Given this list of marker genes Rbm14, Zic3, Leo1, Bmp4, Wnt5a, Paf1, Il1rn, Tenm4, Vangl2, Acvr2b, Grb2, Gja1, Bmpr1a, Gata6, Eomes, Nat8f3, Tasor, Nf2, Dkk1, Apoa1, Tal1, Gata4, Col5a2, Lbx2, Map2k1, Frs2, Col11a1 (collagen, type XI, alpha 1), Dact1, Rtf1, Sfrp1, Hhex, Lrp5, Arfrp1, Nog, Col5a1, Kdm6a, Kdm6b, Ets2, Apln, Nr4a3, Scx, Clasp2, Armc5, Elf5, Smad2 (SMAD family member 2), Nphp3 (NCBI Gene Id 74025), Txnrd1, Myadm, Dusp5, Eya1, Dld, Ctnnb1, Ext1, Bmp7, Gpi1, Apela, Prickle1, Amot, Arid1a, Setd2, Hand1, Chrd, Rps6, Smad1, Mesp2, Nsd1, Hnf1a, Col4a2, Fzd7, Hnf4a, Foxf1, Prkar1a, T, Tgif1, Wnt3a, Klf4, Poglut1, Sox17, Zbtb17, Acvr2a, Dab2, Tbx19, Dag1, Aplnr, Nckap1, Pofut2, Ric8a, Col6a1, Macroh2a1, Vtn, Mmp2, Nat8f5, Sox2, Tbx6, Itgb3, Wls, Dusp1, Atoh8, Srf, Wnt5b, Tgif2, Hsbp1, Mesp1, Foxa2, Il10 (NCBI Gene Id 16153), Phldb2, Taf10, Mmp9, Acvr1 (NCBI Gene Id 11478), Dusp2, Nat8f2, Fgf8, Wnt3, Itga5, Foxc1, Tcf3, Snai1, Dvl2, Prkaca, Nat8, Hmga2, Hnf1b, Pax2, Dvl1, Gpc3, Msgn1, Inhba, Nr0b1, Itga3, Cul3, Kif16b, Itga8, Mmp15, Itga2, Tnfaip3, Lhx1, Fgfr1, Lmbrd1, Sfrp2, Ecsit, Htt, Myh9, Lamb3, Smad3, Mmp14, Trp53 (NCBI Gene Id 22059), Lef1, Mbp (myelin basic protein), Pou5f1, Ctr9, Clasp1, Lefty1, Lrp6, Map2k5, Nodal, Gdf3, Macf1, Mixl1, Cer1, Syf2, Itgb4, Rnf2, Ahdc1, Megf8, Ugdh, Col12a1, Dusp4, Etv2, Foxc2, Epb41l5 (erythrocyte membrane protein band 4.1 like 5), Adipoq, Brd3, Twsg1, Bmpr2, Epha2, Osr2, Cfc1, Axin1, Rack1, Sox7, Otx2, Itgav, Zfp568, Cripto, Crb2, Ldb1, Tnrc6c, Ext2, Tgfbr2 (NCBI Gene Id 76304), Smad4, Wnt11, Nanog, Six2, Mapk7, Wnk1, Lama3, Hoxa11, Supt20, Mmp8, Hira, Cdc73, Tlx2, Plpp3, Itgb1, Nat8f1, Phldb1, Exoc4, Fn1, Col8a1, Osr1, here is a description of the gene set: species: Mus musculus Mouse Gene Set: GOBP_GASTRULATION A complex and coordinated series of cellular movements that occurs at the end of cleavage during embryonic development of most animals. The details of gastrulation vary from species to species, but usually result in the formation of the three primary germ layers, ectoderm, mesoderm and endoderm.